The following is a description of a gene set: Genes down-regulated in erythroid lineage cells by RUNX1-RUNX1T1 fusion. studied in species Homo sapiens The t(8;21)(q22;q22) occurs frequently in acute myelogenous leukaemia and gives rise to the transcription factor fusion protein, RUNX1-RUNX1T1 (also known as AML1-ETO). To identify the genes dysregulated by the aberrant transcriptional activity of RUNX1-RUNX1T1, we used microarrays to determine the effect of this mutation on gene expression in human progenitor cells and during subsequent development. Gene signatures of these developmental subsets were very dissimilar indicating that effects of RUNX1-RUNX1T1 are highly context dependent. We focused on gene changes associated with the granulocytic lineage and identified a clinically relevant subset of these by comparison with 235 leukaemia patient transcriptional signatures. We confirmed the overexpression of a number of significant genes (Sox4, IL-17BR, CD200 and gamma-catenin). Further, we show that overexpression of CD200 and gamma-catenin is also associated with the inv(16) abnormality which like RUNX1-RUNX1T1 disrupts core binding factor activity. We investigated the functional significance of CD200 and gamma-catenin overexpression in normal human progenitor cells. The effect of IL17 on growth was also assessed. Individually, none of these changes were sufficient to recapitulate the effects of RUNX1-RUNX1T1 on normal development. These data provide the most comprehensive and pertinent assessment of the effect of RUNX1-RUNX1T1 on gene expression and demonstrate the highly context-dependent effects of this fusion gene. Human Gene Set: TONKS_TARGETS_OF_RUNX1_RUNX1T1_FUSION_ERYTHROCYTE_DN from publication Tonks A, Pearn L, Musson M, Gilkes A, Mills KI, Burnett AK, Darley RL (PMID 17898786), and this is the list of marker genes: AHSP, LDLRAD4 (low density lipoprotein receptor class A domain containing 4), ASAP2, LRRC61, GP1BB, MYL4, LTBP1, COL18A1, PDLIM1, CLC, IL9R, ARHGAP22, HBA1, MYLK, LTC4S, SLC27A2, HBE1, PF4, ITM2A